The following is a description of a gene set: Mouse Gene Set: GOBP_REGULATION_OF_HYALURONAN_BIOSYNTHETIC_PROCESS species: Mus musculus Any process that modulates the frequency, rate or extent of hyaluronan biosynthetic process., and this is the list of marker genes: Has2, Smpd3, Pdgfb, Ptger4, Cltc, Egf, Nfkb1, Ap2a1, Tgfb1